The following is a description of a gene set: species: Mus musculus Mouse Gene Set: GOCC_MICROTUBULE_CYTOSKELETON The part of the cytoskeleton (the internal framework of a cell) composed of microtubules and associated proteins., and this is the list of marker genes: Ccdc146, Camk2b, Cstpp1, Dtx4, Bcl2l10, Kif2a, Cdkl5, Cnp, Ribc2, Hspa8, Dzank1, Kif2b, Capn7, Cul3, Spin1, Ccdc85b, Nckap5, Trip10, Champ1, Ftcd (formiminotransferase cyclodeaminase), Slc25a5, B9d1, Pfdn1, Phf1, Topors, Pierce2, Atp2b4, Ythdf2, Cep295nl, Ppp4r2, Bag2, Ranbp10, Sclt1, Ift27, Pclaf, Zzz3, Sctr, Axdnd1, Klf4, Cyth4 (NCBI Gene Id 72318), Poc5, Specc1, Tapt1, Odam, Pde4dip, Kif27, Septin11, Septin8, Agbl4 (NCBI Gene Id 78933), Rab11fip5, Frmd8, Arl2, Chmp2b, Spag4, Zfp322a, Haus1, Cdc27, Psen2, Top2a, Dnali1, Cdc6, Cabcoco1, Dhx9, Fer, Patj, Kifc2, Rilp, Cpeb1, Magi2, Ttll13, Slc16a1, Tubb4b, Mapk1, Gpsm2, Mtcl1, Prkaa1, Mphosph9, Dcxr, Arhgap4, Plekha7, Atf4, Dnajb3, Map7, Utrn, Kcnab2, Map9, Kat2a, Zbtb49, Actr1a, Cep20, Ndc80, Usp50, Firrm, Ptpn7, Mapre3, Dnah14, Gas2l3, Cfap161, Ecpas, Ccdc65, Cdh26, Rabgap1, Aurka, Wdr73, Afg2b, Kif3c, Bcl2l1, Cul7, Ift57, Ccdc77, Eps8l2, Polb, Cct3, Mcph1, Mical1, Mfap1a, Crmp1, Spatc1l, Sema4d, Cfap126, Clmp, Tmem9, Cep97 (centrosomal protein 97), Chmp2a, Cibar2, Tube1, Stk3, Stard9, Ppp2ca, Crocc, Map2k5, Aunip, Camsap3, Tex35, Dnah17, Dido1, Zfp12, Ttll11, Stx1b, Sntb2, Ccdc14, Evi5, Cdc42ep4, Hepacam2, Ccnd1 (cyclin D1), Fam161b, Etl4, Ercc2, Katnbl1, Cct8, Ttll3, Sptbn5, Chmp1a, Clip4, Cfap95, Zfyve19, Ankrd53, Spdl1, E4f1, Sra1, Myf6, Dvl1, Cimip2b, Zfp397, Bbs2, Sfi1, Wdr35, Deup1, Hnrnpu, Dynlt4, Agbl2, Spmip5, Tubb2b, Taf1a, Ndel1, Tubg2, Lrrc25, Kifc5b, Dctn5, Slc1a4, Shtn1, D7Ertd443e, Spag6l, Ift172, Mpp1, Lztfl1, Apoe, Map3k11, Ccdc78, Lemd2, Cdk5, Chp1, Tsc1, Rapgef6, Cdk2ap2, Strbp (NCBI Gene Id 99105), Eml1, Aaas, Lyst, Rps6ka2, Trim54, Ccsap, Tubb2a, Grip1, Arhgef2, Mycbp2, Mta1, S100b, Ift88 (intraflagellar transport 88), Serp1, Rtraf, Aurkb, Ccdc116, Stk33, Ccdc88a, Lzts2, Spmip9, Cep83, Cep131, Entr1, Rab11a, Lrwd1, Fhdc1, Ppp1r12a, Bbs1, Ppp1cc, Cdc42, Rabl6 (NCBI Gene Id 227624), Kif1a, Cct6a, Adcy10, Or2a7, Lrrc45, Map6d1, Hmbox1, Fam184a, Pcif1, Kif14, Ccnj, Arl8b, Nudc, Mast2, Scyl1, Ddx3x, Eya3, Enkur, Cdc14a, Septin4, Nek6, Septin2, Arl13b, Dynll1, Cilk1, Gsk3a, Srprb, Sfr1, Mllt11, Kif19b, Cfap276, Acads, Enkd1, Cdk10, Ruvbl1, Kif3b, Saa1, Nfe2l2, Cetn4, Capn6, Stmn1, Trpv4, Tbccd1, Prpf6, Fbxl7, Nr3c1, Tpt1, Efcab6, Mad1l1, Kif5c, Klhl4, Cimap3, Plekhg6, Cimap1d, Proser3, Kif19a, Ckap2, Khdc3, Ccdc68, Pkn2, Cfap210, Togaram2, Hook2, Mapk14, Prkcz, Bloc1s2, Tacc2, Pmm2, Pqbp1, Tubb1, Brca1, Odf2l, Dynlt5, Chmp6, Dctn1, Tbc1d31, Spag8, Dynll2, Dnal1, Bud31, Txndc9 (NCBI Gene Id 98258), Arl8a, Fign, Dtnbp1, Spef1, Dynlt2b, Ccdc28b, Flii, Actr8, Septin12, Axin1, Sppl2b, Ninl, 4933427D14Rik, Ttll7, Rassf1, Lrrk2, Katnal2, G6pdx, Ppp2r5a, Map4, Ttl, Ctnnb1, Cyld, Cfap221, Arl6, Wdr90, Irs1, Ranbp1, Trat1, Ccar2, Fkbp4, Klc3, Shroom1, Ift81 (NCBI Gene Id 12589), Snx4, Maea, Ush2a, Dync1i1, Ttll5, Polr3h, Kat14, Relb, Anapc7, Dnhd1, Tmem67, Armc9, Ccdc57, Bex4, Mapkapk2, Snx10, Zmynd10, Dzip1, Mapk1ip1 (NCBI Gene Id 69546), Mid2, Bbln, Kpna7, Pkhd1, Sybu, Rab3ip, Dnai2, Sbds, Ehd2, Haus8, Prkcq, Dpf2, Clip3, Rae1, Asap1, Tbl1x (NCBI Gene Id 21372), Map2k1, Cdk1, Cep70, Exoc7, Cfap144, Tubgcp3, Ccdc81, Myo18a, Ercc6l2, Map1b, Tubb3 (NCBI Gene Id 66927), Washc1, Dync1li2 (NCBI Gene Id 234663), Haus3, Uxt, Misp, Cct7 (NCBI Gene Id 12468), Tuba1c, Dync2li1, Pkp4, Umod, Tubb6, Gnai3, Cimip2c, Afg2a, Ciao1, Tbca, Rnf4, Rp2, Ccdc88b, Prc1, Whamm, Kif21a, Septin1, Cep135, Septin14, Trip4, Akna, Opa1, Ubxn6, Ndn, Gpr174, Sac3d1 (NCBI Gene Id 66406), Ttll8, Phlpp2, Pierce1, Wdr11, Hdac3, Trappc14 (NCBI Gene Id 231807), Slc8a1, Lats2, Hook3, Golga2, Dnah2, Ccdc120, Trim69, Kif16b, Cdc25b, Tpr, Svil, Prkacb, Fam110b, Tekt3, Kif9, Ofd1 (NCBI Gene Id 52045), Rpgr, Cfap206, Wdr44, Tektl1 (tektin like 1), Ccdc103, Pycard, Cd86, Pik3r5, Agbl1, Rgcc, Katna1, Cfap52, Kif24, Rlbp1, Cdk2, Kif20a, Hook1, Spef2, Poc1b, Dbt, Ilrun, Rb1, Vcp, Kiz, Vapa, Jade1, Chmp7, Cfap96, Wdr47, Kif26a, Tbc1d30, Tubb5, Kmt5b, Adcy9, Cfap68, Apc, Vps41, Podxl, Reep3, Cenpv, Mcm3, Ttc12, Kifc1, Kif28, Katnb1, Stox1, Nfs1, Ttbk2, Reep1, Nudcd2, Map7d3, Hyls1, Hormad2 (HORMA domain containing 2), Dtl, Rangap1, Tgif2, Cdc7, Atp6v1d, Fgf13, Pdzd7, Dnm1, Kif5b, Eif3a, Alms1, Hk2, Ccne1, Dync2i1, Bcl10, Agtpbp1, Mib1, Ppp1r42, Htt, Plk1, Hnmt, Fbxo5, Tedc2, Ccna2, Wdr62, Matcap1, Myc, Dcaf1, Spag9, Tnks, Fes, Nudcd3, Mad2l1bp, Smc3, Tsks, Mlf1, Cep72, Acaa2 (acetyl-CoA acyltransferase 2), Bod1, Esrra, Hdac6, Mdh1, Chek1, Prkaa2, Dnaaf5, Bccip, Stk11, Mdm2, Cluap1, Rassf7, Cys1 (cystin 1), Ccdc50, Mtcl2, Tmem201, Espl1, Gem, H2ax, Rell1, Borcs5, Rad51d, Baiap2, Rcc2, Pibf1, Wnk1, Rita1, Nup93, Ska3, Odad1, Dr1, Efhc2, Rusc1, Dpp9, Cby1, Uvrag, Rimbp3, Ift80, Mfn2, Dcaf13, Cyp2a4, Kif23, Cdkl2, Tbl1xr1, Snapin, Reep2, Camsap1, Ccnjl, Ypel5, Cbx1 (chromobox 1), Ppp4r3b, Chd4, Sorbs1 (sorbin and SH3 domain containing 1), Tmem237, Tcea2, Dynlt2a1, Ajuba, Il1rn, Nisch, Mad2l1, Micall1, Cep76, C2cd3, Tbc1d7 (NCBI Gene Id 67046), Cep295, Ssx2ip, Tuba1b (tubulin, alpha 1B), Ttll10 (tubulin tyrosine ligase-like family, member 10), Casp1, Shcbp1l, Cbx3, Ofcc1, Haus4, Taok1, Spag17, Septin6, Eef1akmt3, Serinc5, Ubn1, Rgs14, Ttc28, Dst, Dcdc2c, Prkar2a, Pbxip1, Ift140, Dnah6, Rab34, Psmb4, Gabrg3, Ocrl, Mtus1, Arfgef2, Atp6v0d1, Nme7, Ccdc92, Ror2 (receptor tyrosine kinase-like orphan receptor 2), Fnip2, Lca5, Mbip, Clasp2, Nek8, Dnah8, Epb41, Kncn, Als2 (NCBI Gene Id 77293), Ift70a2, Tbcd, Rilpl1, Smc1a, Chmp3, Cib1, Tbck (TBC1 domain containing kinase), Sass6, Keg1, Rassf3, Dyrk1a, Dcun1d5, Tedc1 (NCBI Gene Id 279769), Fntb, Pik3r4, Hspa1a, Fbxw11, Herc2, Kif15, Nsl1, Eml6, Pla2g4c, Rock2, Rab6b, Ttll4, Csnk1d, Diaph3, Iqgap2, Dync1h1, Eml2, Ttc8, Cdc45, Map10, Hsph1, Nin, Tubd1, Macf1, Rmdn2, Smad7, Spast, Ccnd2, Dnah5, Hmmr, Cltc, Rif1, Ccdc15, Mapt, Klhl12, Cct2, Gas2l1, Clrn1, Haus7, Psmc4, Ift52, Atxn7, Fam234b, Zfp365, Il4ra, Tcp1, Ccser2, Arhgef7, Wdr5, Cep162, Gapdh, Ruvbl2 (NCBI Gene Id 20174), Slain2, Myh10, Pdcd6ip, Yes1, Ift43, Ric8b, Klhl22, Mefv, Ik, Cep112, Akt1, Hsf1, Haus6, Csnk1a1, Ect2 (NCBI Gene Id 99670), Itgb1bp1, Kif13a (kinesin family member 13A), Spice1, Cdc20, Dlgap5, Bicd2 (BICD cargo adaptor 2), Tuba8, Septin7, Glg1, Rttn, Mark4, Caprin2, Bbs4, Dbh (dopamine beta hydroxylase), Cep250, Gabarap, Tap1, Cdca8, Cfap53, Ttll2, Rrp7a, Tex9, Rabep2, Ccdc69 (coiled-coil domain containing 69), Pxk, Traf3ip1, Sptan1, Dynlt1b, Poldip2, Lrpprc, Egfr, Ikbkg, Hoxc8, Triobp, Apex1, Ttbk1, Hspa2, Cfap45, Naa40, Nme3, Shmt2, Ppp4r3a, Saa2, Kif20b, Ttc23l, Ino80, Birc5, Daam1, Gtse1, Ssna1, Npm1, Dnah7a, Mad2l2 (MAD2 mitotic arrest deficient-like 2), Anks1b, Odad3 (outer dynein arm docking complex subunit 3), Tm9sf2, Ppp2cb, Spmip4, App, Kif26b, Ptp4a1, Tuba3a, Map1s, Bbs7, Nde1, Ift46, Bag3, Fbxo31, Lrp8, Prkar1a, Daxx, Aamp, Mak, Prkci, Rassf5, Cenpu, Odf2, Katnal1, Ctsc, Dsn1, Pola2, Brsk2, Chodl, Ccdc13, Grb2, Tuba3b, Cfap90, Spry2, Map1lc3b, Bex6, Fmr1, Bcas3, Pin4, Numa1 (nuclear mitotic apparatus protein 1), Hecw2, Rapsn, Irag2, Dnm1l, Tchp, Rps3, Cep57, Knstrn, Kbtbd8, Itgb6, Kif18a, Rad51, Cc2d1a, Dnah1, Ccnb2, Rbbp6, Tada2a, Disc1 (disrupted in schizophrenia 1), Tmem63a, Hoxb4, Eml5, Plk5, Cplane2, Nr0b1, Naa11, Tppp3, Rpgrip1, Iqcd, Pycr3, Cxcr2, Synj2, Cep128 (NCBI Gene Id 75216), Fam83d, Cdk5rap2, Eml4, Tsen2, Procr, Clta, E2f1, Sncg, Cetn1, Ccdc141, Ccnd3, Cep85l, Camsap2, Mastl, Usp2, Kif1b, Dis3l, Kifc3, Rps6ka1, Apc2, Adrb2, Tektip1, Psmd10, Stil, Mt3, Ciao2b, Daw1, Mks1, Ift56, Pcnt, Dennd1c, Meig1, Dnaja1, Chmp1b2, Nphp4, Cep43, Plk3, Map6, Agbl5, Cfap157, Cdk5rap3, Ak5, Hipk1, BC048507, Birc7, Dnah10, Chd3, Dpysl2, Ankrd26 (ankyrin repeat domain 26), Fam110c, Pafah1b1, C2cd5, Tuba1a, Dclre1b, Nsfl1c, Klhl21, Dcdc2a, Aldob, Ift22, Cntrl, Parp4, Acot13, Kif22, Fam110a, Ccnb1, Dnai7, Kif5a, Cntrob, Trim75, Septin10, Gnai2, Upf3b, Tubgcp5, Harbi1, Ngrn, Saxo2, Ush1g, Mapk15, Racgap1, Rragd, Pla2g6, Lrguk, Zfp330, Smad4, Cenpe, Ranbp9, Kif1c, Macroh2a1, Aspm, Nsmce1, Rilpl2, Dnah11, Ift70b, Rab28, Ezr, Dnaaf4, Klc1, Lrif1, Cttn, Spmip6, Rabl2, Myh9, Cir1, Cep120, Cspp1, Clic5, Naa12, Mdm1, Braf (Braf transforming gene), Cct5 (chaperonin containing TCP1 subunit 5), Cfap58, Dnah7b, Ccdc61, Ccna1, Nlrc3, Katnip, Tacc3, Tubal3, Fam161a, Rab11fip3, Fbxl13, Id1, Cdk6, Crhbp (NCBI Gene Id 12919), Nek9, Tubgcp4, Haus2, Nup62, Actr10, Pla2g3, Ccdc18, Invs, Chmp4b, Pja2, Ttll12, Septin3, Map7d1, Dnaaf2, Gas8, Cadps2, Tubb4a, Arhgap6, Kif3a, Dcx, Wapl, Ist1, Cep68, G6pd2, Slc8a2, Bora, Dcaf12, Fkbp6, Ncor1, Rpgrip1l, Ckap5, Taf1d, Dynlt1f, Inppl1, Pak1, Bicd1, Wdr13, Chmp5, Nav3, Ccdc181, Cep152, Tppp2, Dnai3, Ss18, Smg6, Mecp2, Nudt21, Prkar2b, Cetn3, Septin9, Mns1, Bmyc, Rab23, Hras, Wrap73, Pdzd2, Nek4 (NCBI Gene Id 23955), Plk4, Dync2h1, Jtb, Tfdp2, Cenpf, Ccdc38, Prkaca, Limk2, Keap1, Tmem214, Selenos (selenoprotein S), Pard6a, Nubp2, Calml3, Rsph1, Vps4b, Rab3d, Kank4, Ovgp1, Fry, Aurkc, Cep350, Tesk1, Slain1, Rap1gap2, Ilk, Slmap, Dzip1l, Cfap141, Capg, Shcbp1, Ift25, Nme8, Luzp1, Dynlt3, Smc6, Rpp25, Ska1, Arhgef10, Cep85 (NCBI Gene Id 70012), Plag1, Ttll1 (NCBI Gene Id 319953), Psme3, Dctn2, Fsd1 (NCBI Gene Id 93745), Tssk2, Clip2, Stau2, Nuak1, Nav1, Cdc14b, Smad6, Agbl3, Pkd2, Bbs5, Appbp2, Rac1, Pax2, Haus5, Cd180, Tulp3, Kif7, Rmdn1, Map1a, Igbp1, Specc1l, Kif21b, Rab6a, Cenatac, Tubg1, Tnks2, Sgf29, Hspb1, Brca2, Cyp2a5, Bcas2, Clasp1 (CLIP associating protein 1), Rab8a, Slc8a3, Prkca, Gli2, Cep89, Mlph, Cdk16, Clip1, Ckap2l, Lats1, Bub1b, Xrcc2, Kash5, Ccdc42, Ivl, Pcgf5, Ptpn23, Pard3, Cep55, Reep4, Ptk2, Cep41, Dynlt1a, Zfyve26, Gpx2 (glutathione peroxidase 2), Gnai1, Gle1, Slf1, Abraxas2, Yeats2, Nek1 (NIMA (never in mitosis gene a)-related expressed kinase 1), Spout1, Psmb5, Steep1, Kif4, Pcna, Prpf19 (pre-mRNA processing factor 19), Kif13b, Trim32, Zfp207, Dynlrb1, Tekt4, Lsm14a, Ola1, Myof, Hspa1b, Cdh23, Usp33 (ubiquitin specific peptidase 33), Dynlt1c, Anxa11, Akap9, Emd, Tacc1, Skp1, Lck, Nusap1, Cdc42ep2, Gas2l2, Rad18, Cep170, Birc6, Unc119, Mplkip, Dnai4 (dynein axonemal intermediate chain 4), Hnf4g, Tmub1, Tubgcp2, Cep63, Snap29, Spmip8, Psen1, Cfap410, Slc34a1, Lrrcc1, Chmp4c, Pmf1, Atm, Lrrc49, Kif2c, Dcdc2b, Fnta, Ralbp1 (NCBI Gene Id 268968), Topbp1, Mapre2, Zw10, Ccnf, Smo, Rpap3, Trim36, Odf1, Dapk3, Nedd1, Septin5, Cep19, Mzt2, Ppp4c, Cdc42bpg (NCBI Gene Id 240505), Jpt1, Cep44, Ahi1, Ift122, Marchf7, 1700012B09Rik, Sirt2 (sirtuin 2), Cntln, Ddhd2 (NCBI Gene Id 72108), Ccdc124, Abcc3, Cep78, Ctnnbl1, Pskh1, Kif18b (kinesin family member 18B), Spmip10, Ctdp1, Dnai1, Mkks, Bbs9, Dusp21, Mapk3, Orc2, Psma1, Saxo4, Pnma5, Saxo1, Mzt1, Incenp, Dlg5, Rnf19a, Gabarapl1, Pde4b (phosphodiesterase 4B, cAMP specific), Tppp, Mical3, Atf6b, Crocc2, Tiam1, Rassf10, Marcks, Mvb12a, Pcm1, Nckap5l, Cep164, Poc1a, Fmn2, Iqcb1, Chmp1b, Dctn3, Cdkn1b, Cetn2, Dync1i2, Map2k2, Gapdhrt2, Exoc4, Calm2, Shroom3 (shroom family member 3, NCBI Gene Id 52200), Tek, D1Pas1, Mme, Nit2, Cd2ap, Azin1, Pde4d, Ccdc96, Stim1, Cep57l1, Sarm1, Hypk, Arhgap18, Calm1, Ndrg1, Ribc1, Mid1ip1, Actr1b, Dctn4, Cibar1, Dnah12, Gapdhrt, Radil, Mfap1b, Spaca9, Jakmip1, Shroom2 (NCBI Gene Id 670546), Arl2bp, Neil1, Bcl3, Ccp110, Usp9x, Vps37a, Ddx11, Pea15a, Ttc39a, Drc1, Ywhae, Pknox2, Lrriq1, Atat1, Plk2, Slc25a54, Gtf2f2, Dynlrb2, Kif17, Nek2, Stap1, Mtus2, Tada3, Pacsin2, Cchcr1, Tent5c, 2700049A03Rik, Arhgap35, Togaram1 (NCBI Gene Id 328109), Gen1, Rps7, Obsl1, Lhcgr, Ptpn20, Zfp804a, Snph, Nicn1, Cdc16, Intu, Psrc1, Vps4a, Hap1, Ccdc22, Usp20, Dnm2, Cep95, Klc2, Nme1, Gramd2b, Ubr4, Dnah7c, Kif6, Cfap100, Erc1, Ccne2, Ffar4, Bicdl1, Mis12, Dnm3, Fance, Spatc1, Axin2, Kifap3, Dlg1, Cep126, Haspin, Cenpj, Cep104, Ccdc113, Ccdc117, Cct4, Iqgap1, Ift70a1, Dyrk3, Krt18, Rp1, Tubgcp6, Efhc1, Cep192, Ak6, Sdccag8, Cep290, Git1, Map7d2, Ppp4r4, Cracr2a, Kat2b, Klc4, Neil2, Ift74, Brcc3, Nup85, Cep170b, Atf3, Ski, Drd4, Dync1li1, Smad3, Fbxw8, Prkcb, Mms19, Tekt2, Tbcb, Fbf1, Cfap298, Nsun2, Spag5, Ccdc112, Flcn, Cfap20, Tpx2, Stag1, Slc18a2, Ccdc178, Mapkbp1, Zbed6, Akt3, Iqcg, Kif12, Tuba4a, Itsn2, Ppp1r35, Ttll9, Filip1l, Diaph1, Cfap70, Evc, Ubxn2b, Leo1, Dnah9, Kat5, Pinx1, Bcl2l11, Nubp1, Nlrc5, Terf1, Mid1, Klhl42, Ankrd7, Stag2, Map1lc3a, Ift20, Traf5, Atf5 (activating transcription factor 5), Ccdc187, Trim46, Abca2, Brsk1, Dysf, Tpgs1, Spata7, Alpk1, Kmt2e, Nek7, Bysl, Flot1, Cimip2a, Efhb, Nlrp3, Neurl4, Cfap107, Rmdn3, Sting1, Spmip11, Whrn, Fank1 (fibronectin type 3 and ankyrin repeat domains 1), Mapre1, Ttll6, Tsg101, B9d2, Dnah3, Bbof1, Ska2, Anapc5, Tpgs2, Parp3, Ccdc88c, Wrn, Creb1, Rbm39, Ccno, Rrm1, Gsk3b, Trp53, Cfap77, Map2, Ankfn1, Nedd9, Ccnb1-ps, Dctn6, Dync2i2, Chrm2, Hid1, Ppp2r3c, Calm3, Ccdc8, Mamld1, Mx2, Kntc1, Spag6, Arl3, Bin1, Tekt1, Fzd6, Ran, Lrp1, Atxn10, Dnal4, Gpaa1, Tekt5, Sgo1, Pacrg, Bmerb1, Rock1 (Rho-associated coiled-coil containing protein kinase 1), Synj1, Gli1, Kif11, Tcp11l1, Eml3, Ccdc66, Tsga10, Mplkipl1, Clic4, Fez1, Bnip2